Given this list of marker genes Prim1, Pole, Pola2, Pole2, Pola1, here is a description of the gene set: Reactome Pathway: DNA replication initiation part of: Synthesis of DNA species: Mus musculus electronically inferred by orthology from the curated human pathway This event has been computationally inferred from an event that has been demonstrated in another species.<p>The inference is based on the homology mapping from PANTHER. Briefly, reactions for which all involved PhysicalEntities (in input, output and catalyst) have a mapped orthologue/paralogue (for complexes at least 75% of components must have a mapping) are inferred to the other species.